Given this list of marker genes B230219D22Rik (RIKEN cDNA B230219D22 gene), Katnb1 (katanin p80 (WD40-containing) subunit B 1), Sult2a4, Rnf152, Flot1, Krtap17-1, Hnrnpd, Hars2, Tnrc6b, Cd151, Azi2, Serpina3f, Tet2, Pgk1, Acnat1, Hecw2, Ssbp2, Zc3h12c (zinc finger CCCH type containing 12C), Nptn, Scd1, Hpse2, Adamts15, Ccin, Pramel12, Padi2 (peptidyl arginine deiminase, type II), Lrit2, Gprasp1, Krtap10-31, Mlxipl, Yipf4, Gja8, Aqp4, Dapk2, Actr2, Prr16, B3galt5, Nt5c3, Tnfrsf10b, Map4k3, Arid1a (NCBI Gene Id 93760), Sult2a2, Celf2, Swt1, Strbp, Gpatch2l, Ankrd27, Phf6, B3gnt6, Capza2, Ide, Sult2a1, Pcsk5, Rnf20, Kpna1, Smim10l1, Zeb1 (zinc finger E-box binding homeobox 1), Sgsm2, Foxk2, Map3k12, Tspan13, Sycp3, Pfkfb2, Rora, Agpat5, Trappc14, Atp8b2, Hnrnpk, Kctd8 (NCBI Gene Id 243043), Abca1, Fhip1a, Zfp609, Erlin2, Pramel16 (NCBI Gene Id 329984), Ostm1, Cacnb4, Atg14, Kcnc2, Ctbs, Bin1, Bcl7a, Epc1, Neto1, Cd34, Pou3f2, Prkaa1, Zswim5, Gm5878, Map3k7, Thumpd1, Slc25a3, Jcad, Hnrnpm, Tmem87a, Tnp2, Cyld, Abcc5, Cc2d1b, Slc25a14, Srrm2, Arid2, Zbtb7c, Tmem266, Hdgfl3, Wdr6, Sertad4, Pip4p2, Timm22, Adcy3, Zc4h2, Sult2a5, Pard3, Upf3b, Crxos, Cdh1, Tnik, Foxa1, here is a description of the gene set: Mouse Gene Set: MIR_873A_5P Genes predicted to be targets of miRBase v22 microRNA mmu_miR_873a_5p in miRDB v6.0 with MirTarget v4 prediction scores > 80 (high confidence targets). from publication Chen Y, Wang X (PMID 31504780) species: Mus musculus